The following is a description of a gene set: Hypoplasia of the fovea species: Homo sapiens Human Gene Set: HP_HYPOPLASIA_OF_THE_FOVEA Underdevelopment of the fovea centralis., and this is the list of marker genes: PAX6, AP3D1, FZD5, FOXC1, TRIM44, ATF6, PDE6C, BLOC1S3, PRR12, UGP2, GDF3, SLC25A19, SLC38A8, CNGB3, HPS4, PDE6H, NEU1, ITPR1, OCA2, SLC45A2, SLC24A5, CACNA1F, CNGA3, GPR143, MC1R, BLOC1S5, CFAP418, GNAT2, MTSS2, DCT, WT1, HPS5, GDF6, RPGR, TYR, IKBKG